The following is a description of a gene set: Pathway Definition from KEGG: Env -> TNFRSF1A -> (RIPK1+TRADD+TRAF2/5) -> (TAB1/2/3+TAK1) -> IKK -> NFKBIA -> NFKB HIV gp120 to TNF-NFKB signaling pathway. Pathway ID: N00441. Pathway type: Pathogen. Pathway class: nt06516 TNF signaling. Human Gene Set: KEGG_MEDICUS_PATHOGEN_HIV_GP120_TO_TNF_NFKB_SIGNALING_PATHWAY studied in species Homo sapiens, and this is the list of marker genes: RIPK1, TRAF2, MAP3K7, TNFRSF1A, TRAF5, TAB1, NFKBIA, CHUK, TAB3, IKBKB, RELA, TRADD, IKBKG, TAB2, NFKB1